Given this list of marker genes Runx1, Tmf1, Adam10, Gm12888, Nid2, Itpk1, Cdt1, Serpine2, Acvr2b, Kdm5a, Sinhcaf, Ankrd44, Nemf, Meis2, Pawr, Nectin2, Zbtb18 (zinc finger and BTB domain containing 18), Vps37a (vacuolar protein sorting 37A), Map3k4, Raph1, D030056L22Rik, Rbm47, Tshr, Cd151, Fbxw11, Llgl2, G3bp2 (NCBI Gene Id 319444), Dcbld2, Fgf10, Cdk17 (cyclin dependent kinase 17), Pak4, Wnt9a, Rfx3, Pdgfra, Cd2ap, Cks1brt, Sp1, Pnrc1, Cnot7, Tmem62, Adamtsl3, Arhgef3, Sema3a, Slitrk6, Mucl2, Nlk, Wdr47, Tmtc3, Tppp, Dnmt3a, Itgb8, Ak4, Qki, Zhx1, Cnr1, Ptprz1, Acvr2a, Col12a1, Net1, Iffo2, Crebrf, Fam199x, Nedd4, Map3k2 (mitogen-activated protein kinase kinase kinase 2), Agbl3, Fn1, Bhmt2, Fubp1, Fam47c, Nova1, Slc39a10, Gna12, Etnk1, 4933434E20Rik, Lrrc7, Scn7a, Ktn1, Kdm6a, Zng1, Alx4, Pde4b, Tubgcp3, Rb1, Cpeb4, Sh3glb1, Tgif2, Pon2, Dctn4, Cnih2, Psd2, Rimklb, Map3k5, Thbs1, Aplp2, Galnt7, Celsr2 (NCBI Gene Id 53883), Lrp2, Taok1, Katnbl1, Pik3cb, Cdh12, Lin28b, Ppp2r5e, Gpr171, Cd55, Adamts3, Plcb1, Ndrg1, Ube2w (NCBI Gene Id 66799), Rbbp6, Bcar3, Ptpn3, Erbb4 (erb-b2 receptor tyrosine kinase 4), Sos2, Itga3, Abhd4, here is a description of the gene set: Genes predicted to be targets of miRBase v22 microRNA mmu_miR_199a_3p, mmu_miR_199b_3p in miRDB v6.0 with MirTarget v4 prediction scores > 80 (high confidence targets). Mouse Gene Set: MIR_199A_3P_MIR_199B_3P studied in species Mus musculus from publication Chen Y, Wang X (PMID 31504780)